The following is a description of a gene set: studied in species Homo sapiens Reactome Pathway: Nilotinib-resistant KIT mutants Nilotinib is a type II tyrosine kinase inhibitor currently in clinical trials for treatment of KIT-mutant cancers, and shows variable effectiveness against mutations in exon 11, 13, 17 and 18. Nilotinib is ineffective against the gatekeeper mutation T670I. part of: Drug resistance of KIT mutants, and this is the list of marker genes: KIT